Given this list of marker genes TRIM15 (NCBI Gene Id 91943), PPIA, ARK2N, CSNK2B, IL32, BST2, here is a description of the gene set: Human Gene Set: GOBP_NEGATIVE_REGULATION_OF_VIRAL_LIFE_CYCLE Any process that stops, prevents or reduces the frequency, rate or extent of viral life cycle. species: Homo sapiens